The following is a description of a gene set: Human Gene Set: GOBP_ORGANISM_EMERGENCE_FROM_PROTECTIVE_STRUCTURE studied in species Homo sapiens The developmental process in which an organism emerges from a surrounding protective structure such as an egg or pupa case., and this is the list of marker genes: SLC25A34, ZFP14, AKAP3, ZBED6, FBLL1, HS3ST6, STMN3, SUV39H1, NECAB1, ASF1B, TBL1XR1, SMARCB1, CCDC62, RBBP8, LPAR6, NDUFA2 (NADH:ubiquinone oxidoreductase subunit A2), PPP4R4, ST8SIA6, CCDC24, PEMT, CTR9, ARHGDIG, SMIM14, PLPP4, SLC35E2B, PHF6, HCFC1, CMTM3, GRN, BCOR